The following is a description of a gene set: Any process that stops, prevents, or reduces the frequency, rate or extent of hippo signaling. species: Homo sapiens Human Gene Set: GOBP_NEGATIVE_REGULATION_OF_HIPPO_SIGNALING, and this is the list of marker genes: CIT, WWC1, STRN4, VGLL4, MARK3, MAPK14, VCP, PPP2R1A, MAP2K3, SRC, PPP2CA, SLMAP, SIRT1 (NCBI Gene Id 23411), WTIP, DLG5, LIMD1, MOB4, STRIP1, WWC2, AJUBA, SHANK2, SIKE1, STRN3, WWC3